Given this list of marker genes Entrep1, Wbp1l, Trem2, Oxsr1, Stk39 (NCBI Gene Id 99416), Cxcl12, Cxcr4, here is a description of the gene set: studied in species Mus musculus Mouse Gene Set: GOBP_CHEMOKINE_C_X_C_MOTIF_LIGAND_12_SIGNALING_PATHWAY The series of molecular signals initiated by the binding of the chemokine CXCL12 to its receptor on the surface of a target cell, and ending with the regulation of a downstream cellular process, e.g. transcription.